The following is a description of a gene set: studied in species Homo sapiens from publication Griffith AV, Fallahi M, Nakase H, Gosink M, Young B, Petrie HT (PMID 20064453) Interaction of hematopoietic progenitors with the thymic stromal microenvironment induces them to proliferate, adopt the T cell fate, and asymmetrically diverge into multiple T lineages. Progenitors at various developmental stages are stratified among different regions of the thymus, implying that the corresponding microenvironments differ from one another, and provide unique sets of signals to progenitors migrating between them. The nature of these differences remains undefined. Here we use novel physical and computational approaches to characterize these stromal subregions, distinguishing gene expression in microdissected tissues from that of their lymphoid constituents. Using this approach, we comprehensively map gene expression in functionally distinct stromal microenvironments, and identify clusters of genes that define each region. Quite unexpectedly, we find that the central cortex lacks distinctive features of its own, and instead appears to function by sequestering unique microenvironments found at the cortical extremities, and modulating the relative proximity of progenitors moving between them. Genes up-regulated in thymus subcapsular cortical region versus the whole cortex. Human Gene Set: GSE18281_SUBCAPSULAR_CORTICAL_REGION_VS_WHOLE_CORTEX_THYMUS_UP, and this is the list of marker genes: PDE7A, ACAA2, HES6, RAB34, CYP2B6, SLC27A2, AASS, ZHX1, SCG5, PITPNC1, MRPS26, CERK, GP1BB, TAGLN, TSPAN9, RPL31, GNAI1, DECR1, SLC4A5, SLC7A7, CYB5R3, SPSB1, C6orf136, ECHS1, SLC12A7, IL15RA, FHL1, PRKDC, NEDD4L, ADI1, BRIX1, ZNF394, RFC4 (NCBI Gene Id 5984), SPNS1, IFT88, GPAM, AK1, LPIN1, CBR3, YPEL3, CTR9, NEK2, ARRB1, FKBP10, RGL1, RSU1, KLC4, B3GALT2, PAPSS2, VAPB, SIM1 (SIM bHLH transcription factor 1), ZNF362, NLN, CES3, FOXA2, CAPRIN2, PRPSAP1, GCAT, DHRS3 (NCBI Gene Id 9249), LRRC23, RPS6KC1, CREG1, SCD, MOK, ANLN, GSTM5, MXD4, TXNDC16, APBB2, CPT1A, HSD17B10, RGS11, LGALS4, RNASE4, EEF1A2, BATF3, SLC15A2, RASA3, LOX, AKAP7 (NCBI Gene Id 9465), ANK3, CALML4, DNM1, ST3GAL6, HSD17B4, TPK1, KDELR1 (KDEL endoplasmic reticulum protein retention receptor 1), C11orf16, EPHB3, TRAPPC2L, METTL8, TUBA4A, YJU2, MYORG, SLC11A2, MME, AARD, FN1, SLC46A1, NUDT1, TXNIP, CRIP2, SFTPC, ITPR1, SESN1, FHIT, PRDM5, PCCB, NFE2L3, VEGFB, TRAPPC1, ANTXR2, SLC48A1, SPA17, PPOX, MAP1LC3B, SLC2A2, CSAD, IDH2, STRADA, ATP1A1, CYP2S1, TSPYL4, GNE, GNA14, RETSAT, ACYP1, MIF4GD, CYFIP2, ALDH2, SYNCRIP, F5, SPICE1, SEPTIN10, SNAPIN, CBR1, SRI, FMO3, BEX4, RPS6KA2, ECT2, PTPRS, SLC16A7, CDIP1, CDK4, LPP, TEKT1 (tektin 1), ABL1, SMPD2, PSMG1, EXT2, ACTA1, CASP6, SORL1, IL1R1, KITLG (NCBI Gene Id 780897), SPEF1, FANCG, ELF5, SYNRG, PPDPF, NQO1 (NAD(P)H quinone dehydrogenase 1), BPHL (biphenyl hydrolase like), HCFC1, S100G, NPNT, LTBP4, AMPD3, IGF1R, ITGB5, RPL37A, ACSL1 (NCBI Gene Id 91249), CCR4, VPS16, CIPC, ANKH, C12orf43, ESYT3, FBLN2, HACD3, PDCD4, NACC2, NBL1, DAPK2, FCGRT, BMP1 (bone morphogenetic protein 1), AGRP, ACTL6A (actin like 6A), RGS19, CHPT1, LACTB2, NT5DC3, DNAJB13, AOX1, CFAP184, CADM1, EIF2AK4, MICOS13, POR, MIA